The following is a description of a gene set: species: Homo sapiens Human Gene Set: chr1q41, and this is the list of marker genes: RNU6ATAC35P, SNRPEP10, LINC01352, TAF1A, DISP1, CAPN8, FAM177B, PTPN14, PRELID3BP1, MTARC2, RPS15AP12, TLR5, SLC30A10, ENSG00000221673, LYPLAL1-AS1, IARS2, LINC01710, USH2A-AS2, LYPLAL1, DUSP10, ENSG00000236846, UBE2V1P13, HDAC1P2, HLX, ENSG00000300242, LINC02817, GAPDHP24, MIR194-1, RNU6-1248P, MTARC1, RNU6-403P, CAPN2, USH2A, AURKAP1, ACTBP11, MIA3, VDAC1P10, PHB1P11 (PHB1 pseudogene 11), ZC3H11B, LYPLAL1-DT, RNU4-57P, XRCC6P3, KCTD3 (potassium channel tetramerization domain containing 3), TGFB2-AS1, LINC00210, MARK1, KRT18P12, MIR664A, SUSD4, ENSG00000297912, TAF1A-AS1, GPATCH2, CCDC185, NDUFB1P2, RPLP0P5, MORF4L1P1, RAB3GAP2, AIDA, LINC02474, NXNP1, CENPF, QRSL1P2, C1orf115, RNU6-791P, ENSG00000202498, ABHD17AP3, TGFB2, LINC02869, SNX2P1, RNA5SP76, ENSG00000286421, HLX-AS1, RRP15, LINC02779, SNORA36B, USH2A-AS1, BROX, RPL7AP81, UBBP2, TGFB2-OT1, LINC01653, KCNK2 (NCBI Gene Id 3776), ENSG00000212610, SPATA17, RNU1-141P, RIMKLBP2, CICP13, ESRRG, EPRS1, LINC01705, RN7SL464P, HHIPL2, BPNT1 (3'(2'), 5'-bisphosphate nucleotidase 1), SPATA17-AS1, TP53BP2, MRPS18BP1, ENSG00000305575, MIR215